The following is a description of a gene set: studied in species Homo sapiens Human Gene Set: GOBP_RESPONSE_TO_PROGESTERONE Any process that results in a change in state or activity of a cell or an organism (in terms of movement, secretion, enzyme production, gene expression, etc.) as a result of a progesterone stimulus., and this is the list of marker genes: TGFB1, SRC, NKX2-2, GABRB1, THBS1, FOSB, ACOD1, YAP1, NCOA2, WBP2, ABHD2, NR1H3, CD38, CLDN4, TRERF1, CAV1 (caveolin 1), UBE3A, PTGER2, GPI, ERRFI1, SREBF1, ABCB1, TGFB2, RELA, TGFB3 (NCBI Gene Id 7043), DSG2, TACR1, DSG1, NCOA1, TSPO, FOS, CSN1S1, VPS54, TXNIP, SOX10, OXT